The following is a description of a gene set: species: Mus musculus A process that is part of the meiotic cell cycle. Mouse Gene Set: GOBP_MEIOTIC_CELL_CYCLE_PROCESS, and this is the list of marker genes: Ddx4, Ubr2, Zscan21, Mybl1, Pnma5, Sirt2, Sgo1, Slx4, Rnf212, Terb1, Fzr1, Mael, Brip1, Gpr3, Tubg1, Mei1, Spo11, Eme1, Syce3, Mcm4, Nanos2 (NCBI Gene Id 378430), Cks2, Msx2, Ehmt2 (NCBI Gene Id 52041), Meiosin, Meikin, Camk2b, Tex12, Eif4g3, Pkmyt1, Zwint, Tdrd9, Wnt4, Ncapd2, Kif18a, Terb2, Tdrkh, Dazl, Ubb, Prdm9, Suv39h2, Washc5, Gsk3b, Rad50, Dmrtc2, Siah1a, Cdc25b, Ccne2, Tubg2, Chtf18, Trip13, Rad51, Foxj3, Tex15 (testis expressed gene 15 meiosis and synapsis associated), Ankle1, Tex19.2, Ube2b, Dmc1, Pten, Fignl1, Bcl2l11, Top2b, Shcbp1l, Tesmin, Rad54l, Grb14, Ccne1, Golga2, Aspm, Brme1, Nuf2, Stk35, Dcaf13, Spata22, Meiob, Nppc, Spdya (speedy/RINGO cell cycle regulator family, member A), Nsun2, Stag3, Brdt, Tex19.1, Foxj2, 4930447C04Rik, Psmc3ip, Fanca, Spire2, Ncapd3, Tex14, Npm2, Ovol1, Septin1, Gja1, Sycp1, Rec8, Majin, Brca2, Washc1 (NCBI Gene Id 68767), Meioc, Ncaph2, Ing2, Actr2, Pde3a, Ednra, Morc2b, Rad51d, Marf1, Fbxo5, Ereg, Syce1, Cdc25c, Espl1, Hus1, Msx1, Incenp, Ncaph, Ooep, Fbxo43, Zfp541, Btbd18, Chfr, Psmd13, Ankrd31, Actr3, Rad51c, Mastl, Cntd1, Slc25a31, Mcm5, Dmrt1, Cdc20, Ska2, Hsf1, Sycp3, BC005624, Mcmdc2, Topbp1, Npr2, Msh5, Haspin, Hspa2 (NCBI Gene Id 15512), Spin1, Mos, Ccnb2, Tdrd12, Usp17le, Hsf2bp, Smc2, Asz1, 1700028K03Rik, Sirt7, Dicer1, Orc4, Calr, Atm, Ppp2r1a (NCBI Gene Id 76182), Ythdf2, Rpl10l, Trim75, Rnf212b, Bag6, Cpeb1, Mre11a, Lif, Cenpe (centromere protein E), Myh9, Rps6ka2, Ddb1, Edn1, Cenpc1, Fmn2, Knl1, Hus1b, Birc5, Hfm1, Pdik1l, Ndc80, Wee2, Aurka, Rad51ap1, Cdc25a (cell division cycle 25A), Atrx (NCBI Gene Id 67403), M1ap, Dnmt3l, Arhgap33os, Ttk, Zfy2, Sycp2, Ndc1, Ccnb1ip1, Terf1, Rad21l (RAD21-like (S. pombe)), Top6bl, Rmi1, Cyp26b1, Osm, Pttg1, Spire1, Mei4, Mus81, Mcm7, Syce2, Zcwpw1, Lsm14b, Mlh1, Rspo1, Syde1, Top2a, Tex11, Psma8, Mov10l1, Shoc1, Mcm2, Msh4, Stra8, Kash5, Ago4, Cep63, Hormad1, Eme2, Bend2, Ercc4, Wnt5a, Cenpx, Ska1, Hsf5, Rad54b, Mlh3, Rec114, Rad1, Syce1l, Kctd19, Plcb1, Mnd1, Piwil2, Fancm, Mcm6, Ska3, Smc4, Cenps (NCBI Gene Id 69928), Sun1, Sgo2a, Iho1, Fancd2, Rbm46, Mcm3, Catsperz, Mapk15, Plk1